The following is a description of a gene set: Human Gene Set: WP_ENDOTHELIN_PATHWAYS species: Homo sapiens Endothelin pathways, and this is the list of marker genes: EDNRA, EDNRB, CALCA, ADRB1, MAPK1, MT-CO2, GNB5, MYL1, GNG13, PRKCA, ADRA1A, NOS3, RIIAD1, GNA15, NPY, GNAS, PLCB1, RAMP1, MYLK, RAF1, CALM1, ADCY10, PTGIR, GNAI1, EDN1, NPY1R, CAD, CNN1, CALCRL (NCBI Gene Id 10203), MAP2K1 (NCBI Gene Id 5604), ATP2A2, GUCY1B2, ECE1